The following is a description of a gene set: Reactome Pathway: FCERI mediated NF-kB activation part of: Fc epsilon receptor (FCERI) signaling studied in species Homo sapiens The increase in intracellular Ca+2 in conjunction with DAG also activates PKC and RasGRP, which inturn contributes to cytokine production by mast cells. Activation of the FCERI engages CARMA1, BCL10 and MALT1 complex to activate NF-kB through PKC-theta. FCERI stimulation leads to phosphorylation, and degradation of IkB which allows the release and nuclear translocation of the NF-kB proteins. Activation of the NF-kB transcription factors then results in the synthesis of several cytokines. NF-kB activation by FCERI is critical for proinflammatory cytokine production during mast cell activation and is crucial for allergic inflammatory diseases., and this is the list of marker genes: CDC34, FCER1A, IGLV10-54, IGHV3-7, IGLV2-14, IGLC3, PSMA7, CHUK, PSMA1, RELA, IGLC6, IGKV2-29, BCL10, PSMD1, PSMA6, PSMD6, IGKV1D-33, TAB3, IGHV3-33, SEM1, IGLV1-40, IGHV3-53, IGHV1-46, IKBKG, IGLV, IGLC7, PSMC5, IGLV5-45, IGLV1-47, RASGRP2, IGLV1-44, IGKV4-1, CARD11, IGLV4-69, PSMB4, PSMD2, PSMD14, IGKC (NCBI Gene Id 3514), IGHE, TAB2, SKP1, PSMA4, IGLV3-22, IGLV6-57, IGKV2D-30, IGLV3-16, IGHV4-39, IGHV2-5, IGLV4-60, IGLV2-23 (NCBI Gene Id 28813), IKBKB, UBE2D2, BTRC, IGHV2-70, FBXW11, IGKV5-2 (NCBI Gene Id 28907), UBC, IGLV2-18, IGLV2-8, PSMC3, IGHV3-48, IGHV3-23, TRAF6, IGKV1D-16, UBE2V1, IGKV2-28, IGKV1D-12, UBB, IGKV1-33, IGLV3-27, PSMD7 (proteasome 26S subunit, non-ATPase 7), MALT1, IGLV4-3, LYN, IGHV4-34, IGKV3-20, IGLC1, IGHV7-81, IGKV2D-28, IGKV3D-20, IGLC2, IGHV3-30, CUL1, PSMD13, IGHV1-2, IGLV11-55, UBE2D1, IGLV3-1, PSMD11, IGKV2D-40, IGHV3-13, PSMA5, PRKCQ, IGLV3-19, ADRM1, IGHV3-11, IGLV1-36, PSMB2, IGKV2-30, IGHV4-59, IGKV1D-39 (NCBI Gene Id 28893), IGHV, PSMA3, TAB1, MS4A2, PSMC4, PSMB5, IGKV3-11, PSMB7, UBA52, IGLV2-33, UBE2N, MAP3K7, NFKBIA, IGKV1-39, PSMD12, IGKV1-5, PSMB6, IGLV7-43, IGLV7-46, IGLV3-12 (NCBI Gene Id 28802), IGLV3-21, PSMB1, RPS27A, RASGRP4, IGKV1-17, IGLV8-61, FCER1G, IGHV3-9, IGLV1-51, NFKB1, PSMD3, PSMB3, PSMC1, PSMC2, RASGRP1, PSMD8, IGKV3-15, IGKV1-12, IGKV1-16, PSMA2, IGLV5-37, IGHV1-69, IGLV3-25, IGLV2-11, PSMC6, PDPK1